The following is a description of a gene set: mouse primary BMDCs were stimulated with tlr ligands and gene expression changes were profiled on Affymetrix arrays Human Gene Set: GSE17721_CTRL_VS_LPS_24H_BMDC_DN from publication Amit I, Garber M, Chevrier N, Leite AP, Donner Y, Eisenhaure T, Guttman M, Grenier JK, Li W, Zuk O, Schubert LA, Birditt B, Shay T, Goren A, Zhang X, Smith Z, Deering R, McDonald RC, Cabili M, Bernstein BE, Rinn JL, Meissner A, Root DE, Hacohen N, Regev A (PMID 19729616) studied in species Homo sapiens Genes down-regulated in comparison of control dendritic cells (DC) at 24 h versus those stimulated with LPS (TLR4 agonist) at 24 h., and this is the list of marker genes: PANX1, RPS6KA2, STAT5A, DUSP16, GORASP1, SLC28A2, CHORDC1, MPDU1, PAM16, IER5, SLC9A8, WDR6, EPHA1, TPD52L2, DDA1, CRELD1, WRNIP1, CEP164, LAT, COX16 (cytochrome c oxidase assembly factor COX16), AGFG1, ATP6V0B, MRPS2, ZFPL1, ALPK2, C15orf40, SRI, RWDD4, GRINA, GBE1, SUMO3, GBP7, ARCN1, MOCS2, CDK2AP1, STMP1, BCDIN3D, TXNL4A, CACNA2D3, NDUFB3, COL5A1, SNRPD3 (small nuclear ribonucleoprotein D3 polypeptide), LHX2, NR1H3, HTR2B, TMEM183A, RNF126, CHCHD1, STXBP3, TDRD7, CYP2B6, PTGR3, MITD1, ERCC3, VAMP8, PDSS1, GOLIM4, ABCF1, SEMA3C, TUBA1B, TXNDC5, HK1, CLRN3, MRPL55, ETNK1, HAX1, CYP1B1, WDR4, MELTF, BLCAP, PMVK, VPREB3, CHRAC1, SLFN13, LSM14A, ETV3, ODC1, NHERF1, SLC2A1, IMPACT, DNAJC1, PIM1, GPSM1, MIGA2, CPD, PA2G4, DDX39A, TSHZ1, METAP1, P4HA2, ANGEL1, UTP11, UQCC2, TAGLN3, INTS14, ABCE1, HDAC1, RBM8A, QTRT2, NDUFA4, NOXO1, RBM10, ST3GAL5 (ST3 beta-galactoside alpha-2,3-sialyltransferase 5), PSMC2, IBTK, SNRNP27, PIGF, RNF144A, GSAP, EML6, TMEM243, LRRC59, GNB1, SRSF7, MAGED2, FST, SLC41A1, COX17, MTAP, CNN3, CHCHD4, PSMA2, ITGA4, PLK2, PSMA6, KDR, ZNF18, PSME3, BCKDHB, SLAMF6, AMZ2, TUBA1A, TMEM192, TEN1, MFSD8, NUP88, NIT1, C1orf174, GYPC, IRF8, PSMB8, PHF5A, ARHGDIB, FAM98A, ZMPSTE24, LHB, MRPL21, ADGRG1, MAOA, TNRC18, SCNN1B, TM4SF4, PPP1CB, MAP3K6, TINAG, REXO1, SENP2, FKBP1A, PLEKHA1, PMPCB, TGFBI, UBE2I, PTTG1IP, RAB10, CD47, ATXN7L1, BCAM, RAD23A (NCBI Gene Id 5886), TRAF5, C9orf72 (NCBI Gene Id 73205), TMEM33, IER3, DNAJC10, HAT1, TMEM39A, CACYBP, PLS3, RAB23, CCL5, FGF4, RUVBL2, ATOSB, DENND4B, TPBG, PHYHD1, NUDT5 (NCBI Gene Id 11164), UBXN10, ZSCAN22, MTMR14, TTC28, UBOX5, PDE6D, CLCF1, CDKN1A, HINFP, MKKS, CPT2, ZDHHC5, SMC5, SCGB3A1